The following is a description of a gene set: STAT3, an essential transcription factor with pleiotropic functions, plays critical roles in the pathogenesis of autoimmunity. Despite recent data linking STAT3 with inflammatory bowel disease, exactly how it contributes to chronic intestinal inflammation is not known. Using a T cell transfer model of colitis we found that STAT3 expression in T cells was essential for the induction of both colitis and systemic inflammation. STAT3 was critical in modulating the balance of T helper 17 (Th17) and regulatory T (Treg) cells, as well as in promoting CD4+ T cell proliferation. We used chromatin immunoprecipitation and massive parallel sequencing (ChIP-Seq) to define the genome-wide targets of STAT3 in CD4+ T cells. We found that STAT3 bound to multiple genes involved in Th17 cell differentiation, cell activation, proliferation and survival, regulating both expression and epigenetic modifications. Thus, STAT3 orchestrates multiple critical aspects of T cell function in inflammation and homeostasis. Genes up-regulated in CD4 T cells with STAT3 knockout: TGF beta versus TGF beta and IL6. Human Gene Set: GSE21670_TGFB_VS_TGFB_AND_IL6_TREATED_STAT3_KO_CD4_TCELL_UP studied in species Homo sapiens from publication Durant L, Watford WT, Ramos HL, Laurence A, Vahedi G, Wei L, Takahashi H, Sun HW, Kanno Y, Powrie F, O'Shea JJ (PMID 20493732), and this is the list of marker genes: SLF2, TSKS, B3GALT5, ZBTB9, RBMS2, SLC25A28, LHX8, MCFD2, CCDC160, ZNF354C (zinc finger protein 354C), SIKE1, PARD6G, IDH2, PGM2L1 (phosphoglucomutase 2 like 1), GRIA3, APOL2, KLHDC2, SLC17A9, ZNF281, ATXN1L, MATR3, BET1L, RCN1, CCDC88C, NHLRC3, ACVR1B, DENND6A, FRS2, TPP1, TLNRD1, DNASE1, CHCHD2, TCEANC, STRC, TPT1, GPD1L, FBXL4, KLF13, DYRK2, DSE, SLC2A9 (NCBI Gene Id 56606), CFAP57, KCNIP4, FOCAD, CCR7, ZNF652, RREB1, C6orf136, AP1AR, CERS2, UBE3D, SPR, TOMM20, TUBB2A, FYCO1, FRMD4A, DAG1, DNAAF11, SMIM14, PDE3B, SELENOS, USP40, CARD6, VPS37B, DPH6, PTOV1, TIMM8A, GBP7, MRM1, MESD, DUSP12, HOXB6, MBNL2, DDX25, TSPAN9, SPRYD4, SMURF2, FLOT1, LRRC58, USP12, PCCA, METTL27, UBE2D2, CA12, KBTBD13, KRAS, CHST15, ABCE1, PARP8, TSC22D1, CAPS2, ASCL1, NEDD9, CEBPZ, RBMXL2, CNGA1, MAP3K3, TIMM9, PRMT7, GOLT1A, NSUN2, SLC38A2, NDUFAF4, XRN2, KLRD1, NDST1, GPRC5D, MAK16, RPS25, NOL8, UTP25, CHD9, KRBA1, PADI2, PRDM2 (PR/SET domain 2), BCL2, PAPOLG, KCP, HERPUD1, ITPRIP, PPP3CA, WDR46, HACD4, ATP1B1, TAGLN2, ACP5, PIK3R5, KTI12, BTBD19, RGMB, GALC, DNAJB9, WFIKKN2, MTG1, PLBD2, HLA-DRB1 (NCBI Gene Id 730415), TEX12, C8orf82, CTU2, CDC14B, ADCY6, YTHDC1, IGLC7, PIK3IP1, MAT2A, CITED2, PLA2G4D, PLG, RNF4, SMAP2, SKIC3, APPL2 (NCBI Gene Id 55198), CREBL2, FAM8A1, GAA, GPR180, GNS, CEP104, NCF1, PPAN, CXXC5, TUBA1A, RRP12, PDK1, SMYD3, MCOLN2, DBT (dihydrolipoamide branched chain transacylase E2), FAM174A, SGK3, USP28, BRD2, SWSAP1, PIGT, PIK3CA, PCM1, TDRD3, DCTN6, IKBKG, PDE2A, PATZ1, DANCR, VAX2, CNKSR3, CMTM6, IL1RL2, GOLM2, DNAJB1, ARHGEF12, PDLIM5, FAM53A (family with sequence similarity 53 member A), LYPD6B, METTL18, CD69, LRRC39, NIPAL1, STX2, SIMC1, DCLRE1B, CCM2, PHF20